The following is a description of a gene set: studied in species Homo sapiens Any process that activates or increases the frequency, rate, or extent of a process that reduces the internal pH of a cell. Human Gene Set: GOBP_POSITIVE_REGULATION_OF_CELLULAR_PH_REDUCTION, and this is the list of marker genes: CA2, AVP, UBE3A, AVPR1A, CA7